The following is a description of a gene set: species: Homo sapiens Catalysis of the removal of a methyl group from a modified lysine residue at position 4 of the histone H3 protein. Human Gene Set: GOMF_HISTONE_H3K4_DEMETHYLASE_ACTIVITY, and this is the list of marker genes: RIOX2, KDM5C, KDM5D, KDM5B, KDM1B, RIOX1, KDM5A, KDM1A